Given this list of marker genes NCAM1, RALGAPA1 (NCBI Gene Id 387984), ULK2, ELMO2, PDXP, PHYHIPL, DIRAS1, BEX2, DUSP26, CAND1, FBXW11, SMAP1, PNMA8A, ASAP2, EIF4ENIF1, ADO, NISCH, MAP1B, ZNF84, PHF2 (PHD finger protein 2), SPAG9, ZFP14 (NCBI Gene Id 57677), NGRN, BTRC, KLHL42, RAN (RAN, member RAS oncogene family), FAM219A (family with sequence similarity 219 member A), CSRNP2, TRIM37, SCARB2, PEG3, ACSL3, NUAK1, GSK3B, GABBR2, WSB2, NAA30, TMEM237, CLASP2, TTL, KIF5C, KIF1B, MAPK8IP2, SPIRE1, NPTX1, CCDC92, ARPP19, NLK, CALM1, RBFOX2, APPBP2, NAB1, CEP170, CDC42BPA, CELF3, PREPL, ABI2, RABGAP1L, HERC2, FAM8A1, SIK3, AMER2, KIDINS220, PTPRD, USP22, here is a description of the gene set: studied in species Homo sapiens Neighborhood of MAP1B Human Gene Set: GCM_MAP1B Neighborhood of MAP1B microtubule-associated protein 1B in the GCM expression compendium